Given this list of marker genes TREM2, CSNK1A1, HSPA8, SIRT2, TRIM31, TRIM65, CARD8, LAMP2, ZDHHC12, ABHD17A, FBXL2, MEFV, CPTP, PYDC2, NLRP2B, NLRC3, IRGM, PYDC1, ABHD8, here is a description of the gene set: species: Homo sapiens Human Gene Set: GOBP_NEGATIVE_REGULATION_OF_NLRP3_INFLAMMASOME_COMPLEX_ASSEMBLY Any process that stops, prevents or reduces the frequency, rate or extent of NLRP3 inflammasome complex assembly.